The following is a description of a gene set: Human Gene Set: DESCARTES_MAIN_FETAL_SQUAMOUS_EPITHELIAL_CELLS The gene expression program underlying the specification of human cell types is of fundamental interest. The study authors generated human cell atlases of gene expression and chromatin accessibility in fetal tissues. For gene expression, the study authors applied three-level combinatorial indexing to >110 samples representing 15 organs, ultimately profiling ~4 million single cells. The study authors leveraged the literature and other atlases to identify and annotate hundreds of cell types and subtypes, both within and across tissues. Our analyses focused on organ-specific specializations of broadly distributed cell types (such as blood, endothelial, and epithelial), sites of fetal erythropoiesis (which notably included the adrenal gland), and integration with mouse developmental atlases (such as conserved specification of blood cells). These data represent a rich resource for the exploration of in vivo human gene expression in diverse tissues and cell types. species: Homo sapiens from publication Cao J, O'Day DR, Pliner HA, Kingsley PD, Deng M, Daza RM, Zager MA, Aldinger KA, Blecher-Gonen R, Zhang F, Spielmann M, Palis J, Doherty D, Steemers FJ, Glass IA, Trapnell C, Shendure J (PMID 33184181) Marker genes curated from the annotated cluster as represented in the Descartes Human Gene Expression During Development database., and this is the list of marker genes: TMPRSS11A, GAN, SPRR1A, FAM83C, KRT15, SERPINB10, PITX1-AS1, DENND2C, GLTP, ZNF185, KLC3, SOX13 (NCBI Gene Id 9580), KRT16, H1-2, CLCA2, A2ML1, GBP6, IL36RN, IKBKB-DT, EPIST, GRHL3-AS1, ZNF750, S100A2, KRT17, SERPINB13, TRIM29, SFN, ITGB1P1, ENSG00000258661, CSTA (NCBI Gene Id 378889), RAPGEFL1, LINC02672, ENSG00000250685, LYPD3, LINC01499, KRT6B, H2BC4, DUOXA1, EPHX3, UGT1A6, ADH7, FOXE1, SLK (NCBI Gene Id 9748), KRT6C, CLCA4, GSDMC, KRT14, TMPRSS11F, PITX1, PART1, NTN1, TIPARP, HEBP2P1, ENSG00000231324, LINC02006, MUC21, TMPRSS11BNL, MIR616, THOC3, GJB5, BNIPL, JUP, PRSS27 (serine protease 27), LINC00393, FAM3D-AS1, SPRR3, S100A14, GTF2IP7, DSP, RNASE7, TMPRSS11D, DSG3 (desmoglein 3), PHLDB3, LY6D, CRISP3, CYSRT1, SERPINB5, CALML3-AS1, SRPX2, ZNF812P, DUOX1, SERBP1P5 (NCBI Gene Id 442112), MAL2-AS1, FUT3, GRHL3, KRT78, RHCG, TMEM80, RNF39, MT2P1, TMPRSS11B, B4GALT4-AS1, UPK3BL3P (NCBI Gene Id 122149306), TMPRSS4, RALA, LINC01932, RNF222, GBP1P1, CRCT1, PIGA, SERPINB11, EDAR, ATP10A-DT (ATP10A divergent transcript), TMPRSS11E, PLEKHN1, SPRR2E (small proline rich protein 2E), SLC28A3, NECTIN1, IRF6, KRT6A, MAL2, SPRR2D, CSTB, APOBEC3B, C15orf48, PGLYRP4, KCNK7, NECTIN4-AS1, EVPLL, CTNND1, CRNN, SPINK5, SPRR2A, NCCRP1, KRT80, CAPN14, STYK1, FOSL1, PKP1, BCAS2